Given this list of marker genes SENP6, SMC4 (NCBI Gene Id 10593), CENPF, MIS12, CENPH, CENPX, NDC80, CENPC, SUGT1, NUF2, CENPE, POGZ, CENPW, CENPA, CENPK, TRAPPC12, KNTC1, CENPT, DLGAP5, RNF4, SMC2, here is a description of the gene set: A process that is carried out at the cellular level which results in the assembly, arrangement of constituent parts, or disassembly of the kinetochore, a multisubunit complex that is located at the centromeric region of DNA and provides an attachment point for the spindle microtubules. studied in species Homo sapiens Human Gene Set: GOBP_KINETOCHORE_ORGANIZATION